The following is a description of a gene set: Human Gene Set: HP_SPOKEN_WORD_RECOGNITION_DEFICIT Reduced ability of lexical discrimination, which refers to the process of distinguishing a stimulus word from other phonologically similar words. Lexical discrimination can be defined as the process of correctly identifying words in the mental lexicon to match the phonological input of a stimulus. Spoken word recognition deficit studied in species Homo sapiens, and this is the list of marker genes: TMEM106B, MAPT, PSEN1, TREM2, CHMP2B, HSD17B10, GRN, VCP, GRIN2A